Given this list of marker genes Msh5, Rad51d, Rad51c, Rad23b, Dmc1, Xrcc2, Mlh1, Msh6, Sirt6, Msh4, Msh3, Rad51, Msh2, Xpc, Xrcc3, Pms2 (NCBI Gene Id 18861), Rad51b, here is a description of the gene set: A molecule that recognises toxic DNA structures, for example, double-strand breaks or collapsed replication forks, and initiates a signaling response. Mouse Gene Set: GOMF_DNA_DAMAGE_SENSOR_ACTIVITY studied in species Mus musculus